Given this list of marker genes HESX1, TTC17 (NCBI Gene Id 55761), STC2, MYO18A, FIZ1, TSSK3, FNDC9, H3-3A, OTX2, DEF6, POU4F1, PROK2, PLEC, SPTLC2, SEPTIN7, CCNY, HIC2, CYBRD1, DDAH2, NDST4, PHF6, ITGA10, IL1RAPL1, EDA, PODXL2, ZNF687, DIDO1, ERRFI1, ANKRD12, ERBB4, FOXO4, COL1A2, RPLP0, DYNC1I1, RAPGEF4, EFNA1, KITLG, GJB4, KCNN3, MTBP, GFI1 (growth factor independent 1 transcriptional repressor), DENND4A, MID1, ERG28, VKORC1L1, APOBR, PLPP3, AP4S1 (NCBI Gene Id 11154), TENT4B, ADAM12, TSC22D3, ST7L, TRIM68 (tripartite motif containing 68), PRELP (proline and arginine rich end leucine rich repeat protein), CLTRN, PRKCQ, SCOC (NCBI Gene Id 60592), LARS2 (leucyl-tRNA synthetase 2, mitochondrial), DHRS4L2, ZNF524, FGF10, PHOX2B, NMI, ZIC4, ACVR1, ADD3, TMSB4XP6, ZNF654, SOX21, SIRPA, HDAC8, GPR85 (G protein-coupled receptor 85), BMPR1B, ATP5MG (ATP synthase membrane subunit g), STAC3, USP1, STAG2, PHF1, ZNF503, CACNA2D3 (calcium voltage-gated channel auxiliary subunit alpha2delta 3), FMNL3, SCN5A, MPPED2, ARHGAP44, SCN3B, LHFPL6, NAV2, MAP2, NTRK2, NEK1, CHRM1, GRIN2B, ICAM4, PPP2R3A, CNTLN, OMG, ZNF710, TMEM182, CAPN1, TM2D3 (TM2 domain containing 3), SEMA6D, FKRP, CLDN5, STRN3, CER1, COL4A5, WT1 (WT1 transcription factor), NDNF, DUSP4, TREML1, OMA1, CCDC174, MAML1 (mastermind like transcriptional coactivator 1), NXPH4, DAAM1, ARSG, TMSB4XP1 (TMSB4X pseudogene 1), TRIM8, NUP54, NMT1, TFAP4, CFAP161, PXN, LENG9, BCL2L1 (BCL2 like 1), RBMS3, CCNJ, STAG1, XRCC1, CYRIA, ZBTB11, UBE2W, DNAJA2 (DnaJ heat shock protein family (Hsp40) member A2), PART1, ARPC2, ZMAT3, PCF11, MYF6, COCH, R3HDM1, GABRA3, SSBP2 (single stranded DNA binding protein 2), KCNIP2, TP53INP2, ESRRB, CNTN1, TNXB, COL12A1, AQP2, ZBTB18, LHX9, KLHL20, PRKCG, ZIC1, MTRFR, GPRC5D, PTGR3, PLP2, DHH, CACNB2, CDC23, BUB3, LRRN4CL, ASPH, HOXA10, KMT2A, MYH1, HIP1R, CRYGD, TFDP2, KLHL3, APBB2, STRN4, CSRNP3, PHEX, HGF, PMCHL1, TSPAN7, SGCD, KLF5, FSIP2, NR2F1, NFYB, SH2D6, ADGRB3, BMX, PDGFB, SRSF8, JPT1, SCN8A, LBX2-AS1, PDLIM2, MOAP1, ESRRG, FCER1A, MGAT4A, NRG1, EPC1, DNAJB4, LRRC4, PALS2, SNX9, PRKN, PDS5B, COLCA1, SDCBP, RAB5B, COLEC10, SESN3 (NCBI Gene Id 143686), DNAJB3, TRPS1, SIPA1, GNAQ, IP6K2, PLAGL2, FGFR1 (fibroblast growth factor receptor 1), FGF12, ARID4A, EMX2, PTH1R, ATP5IF1, TRDN, DCAKD, DBNDD2, GDNF, BAMBI, HOXA5, COL4A6, SOX12, NFATC4, PPP1R9B, PFN2, ZNF521, CASQ2, PDZRN4, EPHA7, TUSC2, C7orf33, LIX1, MGAT1, RAB5C, FOXP2, SLC4A1, BTBD3, INHBC, DMD, NDUFS4, S1PR2, KANK2, KCNQ1DN, DSCAML1, MAP3K5, MEIS1, WNT2B, CDH2, CMKLR1, AGGF1, SPINDOC, PPP3CA, WT1-AS, AXDND1, OR2L13, ARID1A, TEF, MIR646HG, SOX5, DMRT1, PTCHD4, ESRP2, CA3, MAP6, PCDH18, HOXB8, CRKL, SPOCK2, NAV3 (neuron navigator 3), NEK2, GGNBP2, TAS1R2 (taste 1 receptor member 2), CSNK1A1, LTBP1 (latent transforming growth factor beta binding protein 1), NAPB, RAB30, EYA1, CRH, SMARCA2, ASB4 (ankyrin repeat and SOCS box containing 4), SHCBP1L, CRAT, ATOH8, TRIM28, SRGAP2, KLHDC10, PPP2R5E, POFUT1, ABT1, ZNF296, MANF (mesencephalic astrocyte derived neurotrophic factor), DYRK1A, SLC6A1 (NCBI Gene Id 6529), DGKB, TMEM69, NCDN, NAGLU, HID1, JPH1, UBXN10, FGD4, RNF146, SHC3, CLTC, PLEKHM1, B4GALT6, VWA5A, HPSE2, TMSB4X, ZFP91, HEXIM2, DDX4, ROBO4, VIP, TNFAIP8, TMSB4XP8, LRP5, KCNK5, FOXA1 (forkhead box A1), ARX, CBX2, ANKRD28, ITGA8, PCDH17, FGFR1OP2, RGS17, SOX30, FAM216B, PTPA, VDR, FOXG1, WBP1, CSTF3, MRPL13, JADE2, IGF1, ZFPM2, FST, RTN1, FAM83F, TNS1 (tensin 1), PMCH, HSD3B7, TRIML1, PACRG, MYH10, CITED2, GLDN, ID1, PCYT1B, PHC2, ROR1 (NCBI Gene Id 4919), PDGFRA, SLC26A6, EGFLAM, DHRS4, ATP1A2, CRYGS, GSE1, MTA2, LMO7, BRSK2, BCL9, SORBS2, POU2AF1 (NCBI Gene Id 5450), CAPZA1, EIF5, here is a description of the gene set: from publication Xie X, Lu J, Kulbokas EJ, Golub TR, Mootha V, Lindblad-Toh K, Lander ES, Kellis M (PMID 15735639) Comprehensive identification of all functional elements encoded in the human genome is a fundamental need in biomedical research. Here, we present a comparative analysis of the human, mouse, rat and dog genomes to create a systematic catalogue of common regulatory motifs in promoters and 3' untranslated regions (3' UTRs). The promoter analysis yields 174 candidate motifs, including most previously known transcription-factor binding sites and 105 new motifs. The 3'-UTR analysis yields 106 motifs likely to be involved in post-transcriptional regulation. Nearly one-half are associated with microRNAs (miRNAs), leading to the discovery of many new miRNA genes and their likely target genes. Our results suggest that previous estimates of the number of human miRNA genes were low, and that miRNAs regulate at least 20% of human genes. The overall results provide a systematic view of gene regulation in the human, which will be refined as additional mammalian genomes become available. Human Gene Set: AAAYRNCTG_UNKNOWN Genes having at least one occurrence of the highly conserved motif M77 AAAYRNCTG in the regions spanning 4 kb centered on their transcription starting sites. The motif does not match any known transcription factor binding site. studied in species Homo sapiens